Given this list of marker genes Sod3, Mir6417, Gm3283, Gm23015, Stim2, Smim20, Gm20223, Gm23532, 5033403H07Rik, Gm3519, C130083M11Rik, Gm42614, Gm17182, Rbpj, Ppargc1a, Gm40304, Gm8069, Gm24902, Gm24235, Gm8121, Gm30301, Lgi2, Gm42745, Gm10441 (predicted gene 10441), 4932441J04Rik, Gm6615, Gm8115, 1700029E06Rik, Anapc4, Gm17977, 9230114K14Rik, Gm18451 (NCBI Gene Id 100417207), Gm10440, Gm5866, 8030423F21Rik, Zcchc4, Gm23896, Gm43664, Gm18901, Pi4k2b, Gm4962, 4930459L07Rik, Sel1l3, Ccdc149, Dhx15 (NCBI Gene Id 13204), Pcdh7, Gm36814, Gm40319, Cckar, Tbc1d19, Sepsecs, Gm22536, Slc34a2, Tent2-ps1, Gm25513 (predicted gene, 25513), here is a description of the gene set: species: Mus musculus Mouse Gene Set: chr5C1